The following is a description of a gene set: studied in species Mus musculus Mouse Gene Set: GOBP_MITOCHONDRIAL_DNA_REPLICATION The process in which new strands of DNA are synthesized in the mitochondrion., and this is the list of marker genes: Mettl4, Rrm2b, Lig3, Dna2, Rnaseh1 (ribonuclease H1), Polg, Primpol, Tk2 (NCBI Gene Id 57813), Ssbp1, Mtnap1, Polg2, Mgme1, Atg7, Endog, Dnaja3, Rrm1, Twnk